Given this list of marker genes Pik3c2g, Pip4k2b, Pik3cd, Pik3r3, Pip5k1c, Pip5k1b, Pik3c2b, Ipmk, Pik3c3, Pik3r2, Pip4k2a, Pik3c2a, Pi4k2b, Pi4kb, Pi4k2a, Pik3r5 (phosphoinositide-3-kinase regulatory subunit 5), Pikfyve, Pip4k2c, Pik3r1, Pip5k1a, Atm, Pik3ca, Pi4ka, Pik3cb, Pik3r6, Pip5kl1, Pik3cg, here is a description of the gene set: species: Mus musculus Catalysis of the reaction: ATP + a phosphatidylinositol = ADP + a phosphatidylinositol phosphate. Mouse Gene Set: GOMF_PHOSPHATIDYLINOSITOL_KINASE_ACTIVITY